Given this list of marker genes BSND, MC2R (NCBI Gene Id 4158), NNT, CYP11A1, STAR, CLCNKA, CLCNKB, MRAP, AVPR2, TXNRD2, here is a description of the gene set: studied in species Homo sapiens Human Gene Set: HP_HYPERNATRIURIA Hypernatriuria An increased concentration of sodium(1+) in the urine.